Given this list of marker genes PFKP, ATF6, KLRC1, CD44, CHSY1, SERPINB9, F2R, RAP2A, PLEK, ID2, DUSP5, PTTG1, CWC15, RPA2, ANXA4, LEPROT, CRYBG1, AP1S2, ATP6V0C, YAF2, LAMC1, NDUFA1, KLRC2, AHNAK, NDUFS4, RHEB, NR4A1, NFIL3, PTPRE, GBP3, GLOD4, ECH1, TTC39B, GNG10, PHF11, ZWINT, H2BC4, SUB1, NFKBIB (NFKB inhibitor beta), UNC119, NIBAN1, ALCAM, ZDHHC2, SMPDL3B, GEM, TBX21, LRPAP1, SYPL1, ACOT7, CXCR3, IL18R1, GIMAP1, ITGAX, SLA, ENTPD1, TXNDC17, HACD2, PMAIP1, PRKAR2A, SSR1, F2RL2, GNA15, PIK3AP1, TMEM167A, RAP1GAP2, IFNGR1, S1PR5, SDF2L1, CCDC50, NCALD, APOBEC2, GNG2, AIF1, MAP1LC3B, UFC1, MYADM, PTPRJ, CCZ1, CASP1, S100A13, YBX3, S100A9, CAPN2, PHLDA1, GPR55, NQO2 (N-ribosyldihydronicotinamide:quinone dehydrogenase 2), S100A8, ELOB, NELFE, RORA, ABHD5, CARHSP1, ITGAL, PRF1, NUDT4, ARHGAP18, CALM2, DGKH, CRIPT, CYRIA, ATP2B4, CD48, SLC4A7, INTS12, SLAMF7, TNFSF9, ANXA1, DOCK5 (dedicator of cytokinesis 5), ZEB2, S100A11, SRGN, SCFD2, PPM1J, NKG7, AP3S1, SAP30 (Sin3A associated protein 30), SPN, BAG1, DSTN, CHPT1, UAP1L1, COQ10B, CXCR6 (C-X-C motif chemokine receptor 6), ITGB1, NBEAL2, ELOA, BLVRA, GIMAP7, CD63, ZYX, TTC39C, COBLL1, COX17, REEP5, MPHOSPH6, PRR13, SELENOM, SYAP1, GMFG, SPTY2D1, ING2, MYO1F, FTH1, ATP6V1F, CCL5, MED7, GSAP, ASRGL1, CHST11, RILPL2, RMDN2, RBM47, DDX28, NDUFS6, CDC42EP3, IFNG, MICAL1, GALNT3, CCL4, PLSCR1, IL18RAP, PRDM1, BHLHE40, NDFIP1, LAIR1, INSL6, SYTL2, MTPN, CYSLTR2, IER2, RGS1, CMC1, CX3CR1, GGH, STARD10, SNX10, RUNX2, HAUS4, here is a description of the gene set: Human Gene Set: GSE15330_MEGAKARYOCYTE_ERYTHROID_VS_GRANULOCYTE_MONOCYTE_PROGENITOR_UP Genes up-regulated in megakaryo-erythrocyte progenitors versus granulo-monocyte progenitors. from publication Ng SY, Yoshida T, Zhang J, Georgopoulos K (PMID 19345118) Regulation of lineage potential and transcriptional priming by Ikaros. New insight is provided into a bivalent regulation of lineage priming in the HSC and its lympho-myeloid restricted progeny the LMPP by the lymphoid lineage-determining factor Ikaros Whereas Ikaros is responsible for the activation of a cascade of lymphoid expression programs and for the establishment of lymphoid potential from the HSC to the LMPP it is also responsible for the repression of stem cell and erythroid genetic programs that are incompatible with further lineage restrictions emanating from the LMPP species: Homo sapiens